Given this list of marker genes Slc38a9, Pcna, Psmc3ip (proteasome (prosome, macropain) 26S subunit, ATPase 3, interacting protein), Rragc (NCBI Gene Id 54170), Lamtor3, Bmp6, Inhba, Lamtor2, Rraga, Lamtor4, Lamtor1, Flcn, Bmp2, Fnip2, Lamtor5, here is a description of the gene set: Mouse Gene Set: GOCC_ENZYME_ACTIVATOR_COMPLEX A protein complex capable of activating an enzyme. Activating subunits may dissociate from the catalytic unit before the enzyme is active. studied in species Mus musculus